The following is a description of a gene set: Human Gene Set: GOMF_TPR_DOMAIN_BINDING species: Homo sapiens Binding to a tetratricopeptide repeat (TPR) domain of a protein, the consensus sequence of which is defined by a pattern of small and large hydrophobic amino acids and a structure composed of helices., and this is the list of marker genes: RAB8B, SRP72 (NCBI Gene Id 6731), STUB1, PDE2A (NCBI Gene Id 5138), TRAK1, HSP90AA1, HSP90AB1, TRAK2